The following is a description of a gene set: Mouse Gene Set: MIR_7687_5P studied in species Mus musculus from publication Chen Y, Wang X (PMID 31504780) Genes predicted to be targets of miRBase v22 microRNA mmu_miR_7687_5p in miRDB v6.0 with MirTarget v4 prediction scores > 80 (high confidence targets)., and this is the list of marker genes: Arhgap23, Hoxc10, Hes3, Ski, Sv2c, Aplf, Prok2, Nr0b1, Grm4, Sp2, Pax2